Given this list of marker genes GSK3B, PARP14, PARP4, PARP16, PARP9, UBE2I, N, GSK3A, PARP8, PARP6, SUMO1, PARP10, here is a description of the gene set: part of: Translation of Structural Proteins Nucleoprotein, the most abundant viral protein expressed during infection, is found in the cytosol and plasma membrane. After phosphorylation and sumoylation it trimerizes and is moved to the Golgi, the virion budding site. Reactome Pathway: Maturation of nucleoprotein_9683610 studied in species Homo sapiens